Given this list of marker genes ILF3-DT, MBNL1, IGF1, STARD13, C12orf50, CACNG3, NUMB, HOXC4, CALD1, MITF, MBNL2, SPRY4, CDK6, PCLAF, SRSF8, KLF7, FEZF2 (NCBI Gene Id 94016), CREB5, DLG2, PROX1, GRAP2, INO80, MAPK9, DENND4C, PLA1A, NR2E1, PLEKHA7, NR1D1, TCF12, MEIS2, LMO1, NCAM1 (neural cell adhesion molecule 1), ANGPT1, CPT1A, SALL3, RING1 (ring finger protein 1), COL1A1, FUT11, NAV3, PRDM8, DLX5, EBF2, HMGB1, HIC2, SLC5A3, MACIR, FLI1, SPINK5, DACT3, PDE1B, TLE4, GTF2A1, WNK4, TOM1, YARS1, MPP2, ZNF281, EXT1, SPATA31H1, NFYB, GNAT1, HOXC6, DAXX, AMBN, RAB3C (RAB3C, member RAS oncogene family), KCTD15, EHF, GRIA3, PLPP1 (NCBI Gene Id 94702), ZIC1, DLX1 (NCBI Gene Id 1745), HTR7, INTS12, DHCR24, COL4A5, ZC2HC1C, SKA2, SLC2A12, NSG2, EYA1 (EYA transcriptional coactivator and phosphatase 1), ELAVL2, HOXA10, GRHL3, EDA, GSTCD, NR4A3, DCX, GNB4 (NCBI Gene Id 59345), COL4A6, CTNND2, INHA, MMGT1, IGSF22, ZIC4, WNT9A, ERBB4, FOXP2, SLC1A3, HSD3B7, OTP, PHF6, MIR137HG, SETD2, SERPINH1, SALL1, ILF3, FKBP11 (NCBI Gene Id 51303), ZMYND8, MPPED2, FGF10, NLK, HOXA2, SRSF6, NDST4, LGI1, TSC1, NFIB, TCF7L2, here is a description of the gene set: Human Gene Set: COMP1_01 studied in species Homo sapiens Genes having at least one occurrence of the motif NVTNWTGATTGACNACAAVARRBN in the regions spanning 4 kb centered on their transcription starting sites. This matches the MYOG transcription factor binding site V$COMP1_01 (v7.4 TRANSFAC).